Given this list of marker genes SLC2A11, SLC5A9, SLC5A10, SLC2A2, SLC2A4, FGF21, SLC5A2, SLC2A3, SLC2A9, SLC50A1, SLC2A6, SLC2A1, MIR32, SLC5A1, SLC60A2, SLC2A14, SLC2A10, SLC2A8, SLC2A7, SLC45A3, SLC2A12, SLC5A4, here is a description of the gene set: Reactome Pathway: Cellular hexose transport Two gene families are responsible for glucose transport in humans. SLC2 (encoding GLUTs) and SLC5 (encoding SGLTs) families mediate glucose absorption in the small intestine, glucose reabsorption in the kidney, glucose uptake by the brain across the blood-brain barrier and glucose release by all cells in the body. Glucose is taken up from interstitial fluid by a passive, facilitative transport driven by the diffusion gradient of glucose (and other sugars) across the plasma membrane. This process is mediated by a family of Na+-independent, facilitative glucose transporters (GLUTs) encoded by the SLC2A gene family (Zhao & Keating 2007; Wood & Trayhurn 2003). There are 14 members belonging to this family (GLUT1-12, 14 and HMIT (H+/myo-inositol symporter)). The GLUT family can be subdivided into three subclasses (I-III) based on sequence similarity and characteristic sequence motifs (Joost & Thorens 2001).<p>Hexoses, notably fructose, glucose, and galactose, generated in the lumen of the small intestine by breakdown of dietary carbohydrate are taken up by enterocytes lining the microvilli of the small intestine and released from them into the blood. Uptake into enterocytes is mediated by two transporters localized on the lumenal surfaces of the cells, SGLT1 (glucose and galactose, together with sodium ions) and GLUT5 (fructose). GLUT2, localized on the basolateral surfaces of enterocytes, mediates the release of these hexoses into the blood. GLUT2 may also play a role in hexose uptake from the gut lumen into enterocytes when the lumenal content of monosaccharides is very high (Kellet & Brot-Laroche 2005) and GLUT5 mediates fructose uptake from the blood into cells of the body, notably hepatocytes.<p>Cells take up glucose by facilitated diffusion, via glucose transporters (GLUTs) associated with the plasma membrane, a reversible reaction. Four tissue-specific GLUT isoforms are known. Glucose in the cytosol is phosphorylated by tissue-specific kinases to yield glucose 6-phosphate, which cannot cross the plasma membrane because of its negative charge. In the liver, this reaction is catalyzed by glucokinase which has a low affinity for glucose (Km about 10 mM) but is not inhibited by glucose 6-phosphate. In other tissues, this reaction is catalyzed by isoforms of hexokinase. Hexokinases are feedback-inhibited by glucose 6-phosphate and have a high affinity for glucose (Km about 0.1 mM). Liver cells can thus accumulate large amounts of glucose 6-phosphate but only when blood glucose concentrations are high, while most other tissues can take up glucose even when blood glucose concentrations are low but cannot accumulate much intracellular glucose 6-phosphate. These differences are consistent with the view that that the liver functions to buffer blood glucose concentrations, while most other tissues take up glucose to meet immediate metabolic needs.<p>Glucose 6-phosphatase, expressed in liver and kidney, allows glucose 6-phosphate generated by gluconeogenesis (both tissues) and glycogen breakdown (liver) to leave the cell. The absence of glucose 6-phosphatase from other tissues makes glucose uptake by these tissues essentially irreversible, consistent with the view that cells in these tissues take up glucose for local metabolic use.<p>Class II facilitative transporters consist of GLUT5, 7, 9 and 11 (Zhao & Keating 2007, Wood & Trayhurn 2003). part of: SLC-mediated transmembrane transport species: Homo sapiens